The following is a description of a gene set: studied in species Mus musculus Mouse Gene Set: GOBP_NUCLEOLAR_CHROMATIN_ORGANIZATION Any process that results in the specification, formation or maintenance of the physical structure of nucleolar chromatin., and this is the list of marker genes: Phf8, Suv39h1 (suppressor of variegation 3-9 1), Rrp8, Bend3 (BEN domain containing 3), Ddx11, Sirt1, Sirt2, Phf2, Smarca5, Baz2a